The following is a description of a gene set: Human Gene Set: GSE36392_EOSINOPHIL_VS_MAC_IL25_TREATED_LUNG_UP Many symptoms associated with allergic asthma result from the sequelae of type 2 inflammation. Interleukin (IL)-25 promotes type 2 inflammatory responses, and T2M cells represent an IL-4 and IL-13 producing granulocytic IL-25 responsive population. We used microarrays to characterize the gene expression profile of T2M cells, and compared T2M cells to other inflammatory subsets (eosinophils, neutrophils, and macrophages) in the lungs of mice with IL-25-induced pulmonary inflammation. studied in species Homo sapiens from publication Petersen BC, Budelsky AL, Baptist AP, Schaller MA, Lukacs NW (PMID 22543263) Genes up-regulated in comparison of eosinophils treated with IL25 versus macrophages treated with IL25., and this is the list of marker genes: P2RX2, BPIFB3, SPINK4, SMAD9, KCTD12, GZMM, PRDM1, BPIFB2, TAFA2, NEXMIF, NPNT, SMTNL1, INSRR, CD14, HOXB1, SLC1A6, SNX16, HAS1, ACE2, CACNG2, CALB2, NPAS3, GCGR (NCBI Gene Id 2642), SQOR, FJX1, SOX2-OT, IL15, SUN2, TSSK3, APOBEC4 (apolipoprotein B mRNA editing enzyme catalytic polypeptide like 4), CSRP3, RASGEF1B, MAGED2, ZBTB12, CYP7A1, NLRP14, NAV3, DCX, EPS8L1, CCDC162P, TEX101, ENTPD8, SLC22A3, LAPTM5, CCDC92, SLC12A1, CLHC1, FAM227A, ATG16L1, HSD17B14, TERB2, NDRG2, CNTN4, ITGB3, GFPT2, RAB1A, LBX1, LRRN2, DSG2, DUSP6, RBM44, IGSF21, B3GNT7, MSLN, THBS2, CCN1, PLEKHH2, P3H4, IPCEF1, GCA, ANKRD37, FBXO11, ASB6, TTPAL, FGL2, ACTRT1, LAMA1, SPATS2L (spermatogenesis associated serine rich 2 like, NCBI Gene Id 26010), FGF4, AK5, CYP2E1, VILL, TBX15, CCNL1, TNFSF14, ACAP1, CACHD1, SLC7A14, NKAIN2, ZSWIM5, MIER3, ANKRD13D, SOX30, CNIH3, UBD, ZDHHC15, SSC4D, BLTP1, RAB37, WASF3, TM6SF1, CKAP2L, OVOL1, DRGX, PITX2, KCTD20, TFEC, PROSER2, IRF2BP2, NKX1-2, PADI4, PWP1, CPXM2 (NCBI Gene Id 119587), CUZD1, FERMT2, ADHFE1, CFAP251 (NCBI Gene Id 144406), PLP1, IL20RA, VWC2L, SLC22A13 (solute carrier family 22 member 13), YPEL5, CRABP2, SEMA5B, PBX1, CSDC2, ARHGAP10, FLYWCH2, SEPTIN14, KRT36, HABP2, SLC16A6, SPOCK2, NMRK2, KCTD8, ARRDC4, ACSBG2, RASL10B, BORCS5, ADAMTSL1, PRICKLE1, FOXF1, ANGPTL8, LPIN2, CLDN8, MAB21L3, PNMA2, SLC6A3, SLC22A2, LRP10, UCN, PELI2 (NCBI Gene Id 93480), FGB, ART5, PTTG1, DUSP1, CCN3, OSR1, TCF23, GJA4 (NCBI Gene Id 2701), SELE, CADM2, ABCB4, RGS4, MCOLN2, MYPN, ACOX2, CFAP206, ACOT4, RNF128, NDUFAF7, TRPV1, POU3F4, SLC7A4, CCDC54, BNIPL, PKDREJ, UNC80, HTRA1, CACNA1E, PDE3A, HOXD3, SOD3, CEACAM20, RHD, PTGIS, CYP8B1, SH2D2A, TMEM88, CYP11A1, PDZD8, LONRF1, SH2D5, HSD11B2, ZNF264, CISH, GPATCH2L, KCNC4, OBP2B, ADIPOR1